The following is a description of a gene set: Progression of prostate cancer to androgen independence is suspected to involve the androgen and protein kinase A (PKA) signaling pathways. Here for the first time, the transcriptomes associated with each pathway and common transcriptional targets in response to stimulation of both pathways were identified in human prostate cancer cells using Affymetrix GeneChip technology (Human Genome U133 plus2). Statistically significant changes in the levels of genes in response to androgen and genes in response to activation of the PKA pathway were determined using GeneSpring software. Expression of a subset of these genes (22) that were transcriptional targets for the androgen and/or PKA pathways were validated by reverse transcriptase-polymerase chain reaction and Western blot analyses. Application of small interfering RNAs to the androgen receptor (AR) revealed that in addition to KLK3, levels of expression of KLK2 and SESN1 were regulated by AR activated by both the androgen and PKA signaling pathways. SESN1 was identified as a gene repressed by activated AR. These results provide a broad view of the effects of the androgen and PKA signaling pathways on the transcriptional program of prostate cancer cells and indicate that only a limited number of genes are targeted by cross-talk between AR and PKA pathways. from publication Wang G, Jones SJ, Marra MA, Sadar MD (PMID 16751804) Genes up-regulated in LNCaP cells (prostate cancer) treated with synthetic androgen R1881. species: Homo sapiens Human Gene Set: WANG_RESPONSE_TO_ANDROGEN_UP, and this is the list of marker genes: DYNLL2 (NCBI Gene Id 140735), TMEM50A, FADS1, GNAI3, CAMKK2, HMGCR, MED28, ZBTB10, BMPR1B, MAP7, KLK3, ATXN3, INSIG1 (insulin induced gene 1), EVI5, CRLS1, MTERF4, ACSL3, PIAS1, UBE2J1, CENPN, SPCS3, MAF, TRGC1, ELK4, SLC30A7, RRP12, KLK2, APPBP2, NGLY1